The following is a description of a gene set: Mouse Gene Set: REACTOME_UBIQUINOL_BIOSYNTHESIS Ubiquinol biosynthesis studied in species Mus musculus, and this is the list of marker genes: Pdss1, Pdss2, Coq5, Coq7, Coq6, Coq4, Coq3, Coq8b, Coq9, Coq2, Coq8a, Stard7, Hpdl